Given this list of marker genes SQSTM1, GSAP, CRIP1, CD40, STAT3, S100A11, CFLAR, NFKBIA, CD44, FNBP1, ARHGAP25, CTSH, BCL2A1, BCL3, MDFIC, here is a description of the gene set: from publication Hummel M, Bentink S, Berger H, Klapper W, Wessendorf S, Barth TF, Bernd HW, Cogliatti SB, Dierlamm J, Feller AC, Hansmann ML, Haralambieva E, Harder L, Hasenclever D, Kühn M, Lenze D, Lichter P, Martin-Subero JI, Möller P, Müller-Hermelink HK, Ott G, Parwaresch RM, Pott C, Rosenwald A, Rosolowski M, Schwaenen C, Stürzenhofecker B, Szczepanowski M, Trautmann H, Wacker HH, Spang R, Loeffler M, Trümper L, Stein H, Siebert R, Molecular Mechanisms in Malignant Lymphomas Network Project of the Deutsche Krebshilfe (PMID 16760442) Down-regulated genes constituting the molecular signature of Burkitt 's lymphoma. Human Gene Set: HUMMEL_BURKITTS_LYMPHOMA_DN studied in species Homo sapiens BACKGROUND: The distinction between Burkitt's lymphoma and diffuse large-B-cell lymphoma is unclear. We used transcriptional and genomic profiling to define Burkitt's lymphoma more precisely and to distinguish subgroups in other types of mature aggressive B-cell lymphomas. METHODS: We performed gene-expression profiling using Affymetrix U133A GeneChips with RNA from 220 mature aggressive B-cell lymphomas, including a core group of 8 Burkitt's lymphomas that met all World Health Organization (WHO) criteria. A molecular signature for Burkitt's lymphoma was generated, and chromosomal abnormalities were detected with interphase fluorescence in situ hybridization and array-based comparative genomic hybridization. RESULTS: We used the molecular signature for Burkitt's lymphoma to identify 44 cases: 11 had the morphologic features of diffuse large-B-cell lymphomas, 4 were unclassifiable mature aggressive B-cell lymphomas, and 29 had a classic or atypical Burkitt's morphologic appearance. Also, five did not have a detectable IG-myc Burkitt's translocation, whereas the others contained an IG-myc fusion, mostly in simple karyotypes. Of the 176 lymphomas without the molecular signature for Burkitt's lymphoma, 155 were diffuse large-B-cell lymphomas. Of these 155 cases, 21 percent had a chromosomal breakpoint at the myc locus associated with complex chromosomal changes and an unfavorable clinical course. CONCLUSIONS: Our molecular definition of Burkitt's lymphoma clarifies and extends the spectrum of the WHO criteria for Burkitt's lymphoma. In mature aggressive B-cell lymphomas without a gene signature for Burkitt's lymphoma, chromosomal breakpoints at the myc locus were associated with an adverse clinical outcome.